The following is a description of a gene set: Genes up-regulated in SARS-CoV-2 infection (ACE2 expressing A549 cells, MOI: 2, 24hpi) Human Gene Set: BLANCO_MELO_COVID19_SARS_COV_2_INFECTION_A594_ACE2_EXPRESSING_CELLS_UP species: Homo sapiens Analysis of the transcriptional response to SARS-CoV-2 compared with other respiratory viruses, including MERS-CoV, SARS-CoV-1 (SARS), human parainfluenza virus 3 (HPIV3), respiratory syncytial virus (RSV), and IAV. from publication Blanco-Melo D, Nilsson-Payant BE, Liu WC, Uhl S, Hoagland D, Møller R, Jordan TX, Oishi K, Panis M, Sachs D, Wang TT, Schwartz RE, Lim JK, Albrecht RA, tenOever BR (PMID 32416070), and this is the list of marker genes: CNIH2 (NCBI Gene Id 254263), EIF1B (eukaryotic translation initiation factor 1B), IFFO1, CTDSP2, AOC3, F3, IL22RA1, ATF3, GMPR, IFNL2, PLEKHA4, RAB30, NT5C3A, PIM1, INO80D, IL6, NEDD4L, TNFRSF9, LTB, SNAI1, IDO1, FOXN2, KPNA5, MXD1, RNASEK, WTAP, TICAM1, KLK14, C3orf38, ELL, ZNF764, GOLGA7B, DBP, HERC6, TCIM, GUCA1B, MBIP, AEBP2, ABTB2, ZNF8, MAFF, PNPT1, ROS1, SCUBE2, FOS, ZEB2, REL (REL proto-oncogene, NF-kB subunit), HS3ST3B1, OTUD3, TNF, CMPK2, PHF21B, BIRC3, HES7, MIR23AHG, XRN1, USP43, MKRN3, ANKRD12, PRKXP1, LCDR, SNHG20, HIVEP2, MXD3, RIGI, CFLAR-AS1, DRD1, CCNT1, BTC, H2BC21, IKZF3, TAF7L, NFKB1, DYNLT2, RASSF8, RIMOC1, LOX, DCHS1, IFITM1, GTF2B, MAFG, CCDC116, UBASH3A, MED26, UBXN7, NFYC-AS1, PIGR, LINC02603, DCP1A, SLC25A28, BBC3, ARL5B, C12orf50, SNORA3B, IFNL3, EFNA3, SNORA8, KLF6, CHST2, IFNB1, NSRP1, AEN, ATP6V1G2, KLHL3, SALL1, ZNF77, PPP1R15B, PRR14, ZNF654, CSKMT, NOD2, CYP27A1, NFKBIA, FERMT3, RBBP6, CCR6, LINC01619, ZNF296, ADAM8, CCDC13, SNORD10, KDM6B, SIX4, EML2-AS1, LMO2 (LIM domain only 2), TANK, CCNT2, CLUHP3, TNFAIP3, HES1 (hes family bHLH transcription factor 1), MPIG6B, PPP4R4, DACT1, CCDC144BP, SERTAD3, SERTAD2, H3C6, SEMA4A, NFKBIZ, HDX (NCBI Gene Id 139324), ANXA2R-OT1, TRIM21, AURKAP1, PROX1, DIRAS1, APRG1, ALDH8A1, CAVIN4, PPTC7, BTN2A1, LIF, SMNDC1, TTC21A, THEMIS2, CXCL3, ZNF547, KLF4, SUZ12P1, ZNF184, USP18, CHP1P2, ZNF280B, SERPINC1, ZNF143-AS1, SPOCK2, H2BC20P, TET3, IL11, DNAJC27, HDAC9 (NCBI Gene Id 9734), PER3, MIER1, MIR4453HG, ODC1, ZNF34, THAP1, NFIL3, CCL20, CCDC85A, DLL1, ZC3H12B, COLEC11, CIART, NHLH1, PRX, PPP4R1L (NCBI Gene Id 55370), CCDC73, ZNF799, PYGM, ZNF222, NR1D1, LINC00472, ZC3H12A, PAXIP1-DT, CFL1P1, SLC6A12, CRY1, SPMIP1, LINC00115, APOBEC3F, ZBTB6, LINC01881, THAP9-AS1, ZNF143, REC8, ZFP36L1 (ZFP36 ring finger protein like 1), TRIM38, ZNF14, NPHS1, DHX58, PARP12, FILIP1L, TAF1D (TATA-box binding protein associated factor, RNA polymerase I subunit D), HOXD11, MIR3685, CD274, GCSAM, NOCT, CD200R1, SLC17A8, ZFP36, IRAK2, KLKP1 (kallikrein pseudogene 1), KDM7A, ZNF292, RSRC2, MIR7-1, TRAF1, LAMP3, CENPA, ZNF567, ACTG1P20, FLT3LG, KDM7A-DT, SKIL, VDR, USPL1, HBP1, SNORA25, MIR497HG, DUSP1, MYNN, GOLGA6C, ILF3-DT, KLF7, OVGP1, KLRC2, BMPER, PNN, PLD6, IFITM3, NKX3-1, IPCEF1, NFKB2, AOC2, RUNX2, WRAP53, ZNF554, STAT2, IRF1, ZNF432, ICAM5, BDKRB2, H2BC18, COL2A1, RAPGEF4, ATP2A1, HLA-F, ALX3, SOCS3, NR4A3, PINLYP, ZNF79, ZNF300P1, RHEBL1, FOSL1, ARID3B, SNORA31, KLF11, CD83, SNORD38B, PCK1, HERC5, TGM2, ZNF267, PPM1E, CCL2, ZNF26, FGF12, HCG27 (NCBI Gene Id 282955), MYOD1, TIGD3, PTX3, OTUD1, ADM5, SERPINA10, MIR221, P2RX5-TAX1BP3, NECAP1, PPP4R2, MED30, EPSTI1, ANKRD49, ZBTB17, RBM39, ZNF821, H4C5, DUSP10, CCDC81, ARL14, SMG1P3, ARC, PCF11, SEMA7A (NCBI Gene Id 8482), ARHGAP19, VAMP2, GCNA, GPR3, SMCHD1, CLEC4A, CCN4, BMP2, NRIP1, ZNF112 (NCBI Gene Id 94538), GPM6B, GZF1, FYB1, TSSK3, LSMEM1 (NCBI Gene Id 286006), CXCL1, SNIP1, BMF, SHOX2, IFI44, ADIRF, TLK2, SUGT1P1, PARP9, CEP85L, RFPL3S, MSC, ZNFX1, FTH1P3, NPTX1, BTG2 (BTG anti-proliferation factor 2), EPM2AIP1, ARHGAP30, CLK4 (NCBI Gene Id 57396), CHASERR, CCNL1, CSRNP1, PROM1, C2, ENSG00000284691, CRTC2, HSH2D, TNFSF13B, ZNF436-AS1, H2AC13, DNAH17, EREG, FBXO48, DUSP8, PLEKHG2, PER1, ZNF101, NRG4, FOXC2, SERPING1, H4C9, ABL2, DDX60L, ADAM32, IL15RA, CCDC144CP, RASGRP3, ZSCAN12P1, LINC01089 (long intergenic non-protein coding RNA 1089), INTS6 (integrator complex subunit 6), HCFC2, FRS2 (NCBI Gene Id 10818), SLC16A14, NFKBIE, TEX29, C11orf91, RND1, DDX60, NIPAL4, LGALS9, CELF1 (NCBI Gene Id 10658), NPC1L1, NFKBID, PARP10, ETV3, GRHL1, SP110, MYSM1, TBC1D15 (NCBI Gene Id 64786), ARID4B, ZBTB21, IER3, SELE, CREB5, CCDC174 (coiled-coil domain containing 174), IKZF5, FBXW7, SUMO4, PPP1R15A, HIVEP1, MLKL, BCL2A1, SOCS1, KCNN1, ZNF57, PLSCR1, GPBP1 (NCBI Gene Id 65056), BST2, ZNF211, CYLD, ZNF555 (NCBI Gene Id 255265), CDKN2AIP, SHFL, NTNG2, MEX3C, TRANK1, MCTP1, CXCL8, RRN3P1, N4BP3, RSF1, ATF4, SRFBP1, ZNG1F (Zn regulated GTPase metalloprotein activator 1F), PNRC1 (proline rich nuclear receptor coactivator 1), CXCL2, H2AC15, CHD1-DT, NR4A1, NAV2, REM2, ALOXE3, SOX9, GBP4, CDK5R1, RASSF5, NEURL3, EFNA1, ADAM20P1, SNHG1, RELB, HYMAI, MIR561, TWIST1, PSMB9, ZNF317, VXN, SNAP25, GADD45A, ZNF136, BHLHE41 (basic helix-loop-helix family member e41, NCBI Gene Id 79365), RNF6, B3GNT5, ZBTB20, IER2, FOSB, CFP, CNTD1, IRF7, RBM48, BATF2, DDIT3, SLA, TBC1D22B, ZEB1-AS1, IFIT5, SNHG10, ARHGAP40, NFE2L2, ZNF627, ZBTB43, ZNF805, PDE4B, ZUP1, AGBL3, KMT2E-AS1, PSMD6-AS2, PSMB8-AS1, PPP1R10, HNRNPU, IFNA22P, LINC00926, HLA-F-AS1, PLEKHF2, HOTAIRM1 (HOXA transcript antisense RNA, myeloid-specific 1), ESRRB, CEBPB, CHD2, POU2F2, GAS2L3, BCL3, CHIC2, DCAF4L1, APOL6, GDF15, CARINH, PER2, RBAK, ZBTB10, CLEC4E, TIPARP, BCL10, ZC3H4, PPM1K, EGR1, GEM (GTP binding protein overexpressed in skeletal muscle), IER5, LINC-PINT, ZNF484, SP100, IL20RB, CNOT4, LAMTOR3, LDHAL6B, MEIS1, MB21D2, INHBA, EPC1, SCARNA15, SLCO5A1, H2AC25, NLRC5 (NCBI Gene Id 84166), MRNIP, NBPF10, ZNF674-AS1, SNORD50B (small nucleolar RNA, C/D box 50B), CCL4, ZNF830, ZNF44, FLCN, OAS3, GNRH1, MDM4, PTGS2